Given this list of marker genes COX7C, RPL22, TMEM147 (NCBI Gene Id 84721), EPB41L3, CRYAB, NAPG, PEA15, TRIM54, EN1, VPS29, ATP2A1, ABCB6, MAN2A1 (NCBI Gene Id 4124), NDRG1, HYCC1, RPL36, WDR5, EPS8, ISCA2, AP3M1, DYNLL1 (NCBI Gene Id 8655, dynein light chain LC8-type 1), LIMS2, ZMAT3, SRSF10, ATP5MF, INSIG2, AQP5, CHCHD4, TNNT2, SPOP, CISD1, VAMP8, PCBP1, H19, CCNG1 (cyclin G1), H2BC4, SEC61B, ROMO1, GNG12, LSM5, HSPA1B, VTI1B, RPS15, PTPN21, NDUFA1, FTH1, VPS26A, FAM89B, XPO1, PSIP1, RRP8, RPS10, UAP1, MARCHF2, SMIM14, VPS54, CRTAP, TNKS2, NACA, VBP1, TRIP6, SDF2, RPS4X, CD81 (NCBI Gene Id 975), CCND3, S100A6, RPS27A, LBR (lamin B receptor), EMC6 (ER membrane protein complex subunit 6), PDPN (NCBI Gene Id 29912), RAB31, PHLDA3, AK1, RPLP0, CMC4, DESI1, DNAJC30, KLF9, IQGAP1, ATP6V0C, ATP5F1E, TIMM8A, CSF1, LXN, LSM10, RPS16, C6orf226, UNC50, CCND1, HIGD2A, VEGFD, TNNI1, FAU, ZDHHC8, PTPN12, ABRACL, GID8, ABHD4, TSPAN5, PSRC1, HOXA11, CUX1, KIF3C (NCBI Gene Id 3797), GAS5, UBE2D2, SERPINE2, ALYREF, MAP1LC3B, COX8A, here is a description of the gene set: species: Mus musculus Insulin-like growth factor 2 (IGF-2) mRNA-binding proteins (IMPs) are a family of posttranscriptional regulatory factors with well-understood roles in embryonic development and cancer but with poorly characterized functions in normal adult cells and tissues. We now show that IMP-2, the most ubiquitously expressed member of the family, is abundant in human and mouse adult skeletal myoblasts, where it is indispensable for cell motility and for stabilization of microtubules. To explore the functions of IMP-2, we analyzed the transcripts that were differentially regulated in IMP-2-depleted myoblasts and bound to IMP-2 in normal myoblasts. Among them were the mRNAs of PINCH-2, an important mediator of cell adhesion and motility, and MURF-3, a microtubule-stabilizing protein. By gain- and loss-of-function assays and gel shift experiments, we show that IMP-2 regulates the expression of PINCH-2 and MURF-3 proteins via direct binding to their mRNAs. Upregulation of PINCH-2 in IMP-2-depleted myoblasts is the key event responsible for their decreased motility. Our data reveal how the posttranscriptional regulation of gene expression by IMP-2 contributes to the control of adhesion structures and stable microtubules and demonstrate an important function for IMP-2 in cellular motility. Transcripts bound to IGF2BP2 complexes and differentially regulated in myoblasts with IGF2BP2 knockdown by RNAi. Human Gene Set: BOUDOUKHA_BOUND_BY_IGF2BP2 from publication Boudoukha S, Cuvellier S, Polesskaya A (PMID 20956565)